The following is a description of a gene set: The directed movement of spermidine, N-(3-aminopropyl)-1,4-diaminobutane, a polyamine formed by the transfer of a propylamine group from decarboxylated S-adenosylmethionine to putrescine, into, out of or within a cell, or between cells, by means of some agent such as a transporter or pore. species: Mus musculus Mouse Gene Set: GOBP_SPERMIDINE_TRANSPORT, and this is the list of marker genes: Slc22a3, Slc18b1, Slc22a1, Slc22a16, Pou2f2